The following is a description of a gene set: studied in species Homo sapiens Human Gene Set: HP_MATERNAL_AUTOIMMUNE_DISEASE A medical history of a fetus or child born to a mother with an autoimmune disease. Maternal autoimmune disease, and this is the list of marker genes: LHX3, TSHR (thyroid stimulating hormone receptor), PROP1, TPO, IYD, LHX4, TSHB, HESX1, DUOXA2, TRHR, POU1F1 (POU class 1 homeobox 1), SLC5A5, TG, DUOX2